The following is a description of a gene set: studied in species Homo sapiens Urea cycle. Pathway ID: N00593. Pathway type: Reference. Pathway class: nt06010 Urea cycle. Pathway Definition from KEGG: NH3 -- CPS1 >> OTC >> ASS1 >> ASL >> ARG1/2 -> Urea+Ornithine Human Gene Set: KEGG_MEDICUS_REFERENCE_UREA_CYCLE, and this is the list of marker genes: ASL, CPS1, ARG1, ARG2, OTC, ASS1